The following is a description of a gene set: studied in species Homo sapiens Human Gene Set: GOBP_POSITIVE_REGULATION_OF_CYTOKINE_PRODUCTION Any process that activates or increases the frequency, rate or extent of production of a cytokine., and this is the list of marker genes: KPNA6, SELENOK, POU2F2, CAMP, FRMD8, ZC3HAV1, CCR7, TREM2, HYAL2, LPL, PLA2R1, EIF2AK2, OPA1, RAB2B, IL17RA, RPS3, PLA2G1B, ADRA2A, PANX2, SECTM1, ADAM10, CD34, FCGR2A, IL12RB1 (interleukin 12 receptor subunit beta 1), ADCYAP1, IL7, UAP1, RARA, TRPV4, TLR1, NLRP1, TSLP (NCBI Gene Id 85480), FLOT1, SPTBN1, GDF2, CYP1B1, IL36A, MAPKAPK2, MAVS, CD86 (NCBI Gene Id 942, CD86 molecule), IRF7, CCR2, NOS2, HPSE, CLNK, XIAP, TRIM32, TXK (NCBI Gene Id 7294), LILRB2, PF4, WNT11, LAMTOR5, TLR4 (NCBI Gene Id 7099), BTNL2, IRF1, CLECL1P, GATA4, IL1RAP, NFATC4, MAPK9, CD4, STING1, FCGR2C, IRAK1, IL6, SCRIB, CD36, CHUK, HGF, ADAM8, SASH3, PAEP, CCL3 (C-C motif chemokine ligand 3), DEFB131A, TANK, DDIT3, HLA-DPB1, USP50, BCL3, MIR132, CD276, HMSD, POSTN, CRTAM, PTPN22, IDO1, CASP1, PARK7 (NCBI Gene Id 113880), IRF5, SETD2, CEACAM20, MAP3K7, DDX1, TBK1, POLR3D, CYBA, VTCN1, CCL1, GPSM3, ADIPOQ, MCOLN2, BSG, PANX1, CX3CL1, FCER1G, TMIGD2, ATF4, KLRC4-KLRK1, TWIST1, NOX5 (NADPH oxidase 5), CLEC5A, IFNG, IL12RB2, IL12A, AZU1, POLR3A, CD74, CD83, C1QTNF3, KIR2DL4, OAS3, IL4R, RELA, ABCC8, HRAS, DENND1B, SERPINB7, XCL1, CHI3L1, IKBKE, IL15, TLR7, IFNGR1, IL6ST, FCGR1BP, CARD9, RIGI, C3, NMB, ISL1, MIR27B, RIOK3, PIK3R1, PANX3, LILRB1, THBS1, UNC93B1, SPON2, CD40LG, CEBPG, SPHK1, TICAM1, CLU, BTN3A1, FFAR3, IL32, RUNX1, PLCB1, STMP1, IL26, IL17RB, RAB7B, DHX9, KPNA2, ADORA2B, IL4, HTR2A, CEBPB, TRIM27, NLRC4, TMED10, HSP90AA1, NLRP2, HAVCR2, CCDC88B, KIT, NLRP9, AGER, NAIP, KAT2A, SULF2, CCBE1, RBM47, NR1H4, NRDC, S100A13, TRAF6, RIPK2, SIRT1, CRLF2, BCL10, SLC7A5, LTB, DRD2, LILRA5, CLEC9A, CADM1, TMF1, LGALS9, RAB1A, NLRP12, RAD21, STOML2, IL6R, C3AR1, SMAD3, GPRC5B, AGPAT1, SETD4, SOD1, SLC11A1, CSF1R, KLRF2, PQBP1, LUM, CAMK4, TLR2, IL1RL2 (NCBI Gene Id 8808), TYROBP, PTPRC, STAT5A, ZBTB7B, CLEC6A, MIR657, MYB, PRKCQ, OAS2, PTPN11, CSF2, PLCG2, CD3E (NCBI Gene Id 916), PYCARD, CD274, B2M, PDE4D, G3BP1 (NCBI Gene Id 10146), CARD11, ARFGEF2, IL33, TRIM56, SLAMF1, CD6, ATP6AP2, TNFSF4, ANXA1, MBP, MIR145, POLR3G, NR4A3, ISG15, POU2AF1, IL21 (interleukin 21), CYRIB, HSPA1A, TYK2, DDX21, EIF2AK3, IRF4, CARD8, NODAL, TLR8, HEG1, CD2, MIR21, RORA, IL17RC, FGR, CLEC12A, HILPDA, CXCL17, IL23R (interleukin 23 receptor), PRKCZ, IRF8, TNF, ALOX15B, IL12B (interleukin 12B), PTGS2, ARID5A, SIGLEC16, NOD1, CYBB, MAPK13, SEMA7A, WNT3A, LY9, KLRK1, DHX36, SYK, NLRP3, AKIRIN2, AIRE, MALT1, HK1, F3, ZNF580, TRIM65, EPHB2, IL16, MIR206, HSPA1B, NLRP10, PNP, XBP1, IRAK3, FFAR2, EBI3, LURAP1, ZBTB20, CD28, HSPB1, NOD2, HMGB2 (NCBI Gene Id 3148), SULF1, LRRK2, IL23A, TMEM106A, TLR5, POLR3B, BTK, IL17A, IL27RA, DDX3X, RGCC, SERPINF2, PRKD2, PTPRJ, IL17B, IL20RB, GSDMD, MIR17, PDE4B, CD46 (CD46 molecule), BRCA1, CASP8, BMPR1A, MMP8, GLMN, ADAM17, LACC1, MIF, CCL19, LBP, ORM2, NOX1, FOXP1, HHLA2, AIM2, HLA-E, EPX, WNT5A, SAA1, ORM1, IL17F, GARIN5A, CD58, DHX33, TRAF3IP3, AGT, EREG, IL27, ARRDC4, STAT3, FCN1, LEP, ROCK2, TLR3, IL18R1, GBP5, AGPAT2, GATA3, SERPINE1, CD160, HLA-A, MAPK14, APOA2, PIK3CG, ARHGEF2, AIF1, FERMT1, SPN, IL2, IL17D, FLT4, IL1A (NCBI Gene Id 3552), DEFA5, TICAM2, MYD88, TIGIT, ATF2, IFNL1, ARNT, RNF135, TRAF3, HTR2B, SPHK2, HIF1A, LAPTM5, C1QTNF4 (NCBI Gene Id 83846), SCIMP, IL10, FADD, IL13, CD14, CALCA (calcitonin related polypeptide alpha), DHX58, IFI16, HLA-G, AFAP1L2, C5AR1, PHB1, FCGR1A, LILRA2, USP22, ELANE, UCN, CREB1, RSAD2, PIK3CD, HDAC2, P2RX7, RAET1G, RFTN1, BATF, TIRAP, AKAP12, IFIH1, STAT1, RTN4, CD81, CD226, MAPK11, IL1B, PTGER4, FCGR3A, ZP3, GPR65, MIR675 (NCBI Gene Id 102724852), TRAF2, TOMM70, FZD5, CHIA (NCBI Gene Id 27159), CGAS, APPL1, INAVA, CLEC4E, DDT, HSPD1, HMOX1, IL1RL1, MIR149, GAPDH, TLR9, BTN3A2 (butyrophilin subfamily 3 member A2), FOXP3, HLA-F, IL18, HMHB1, TNFRSF8, NFAM1, NMBR, MMP12, PLA2G3, LY96, TBX21, ZCCHC3, SORL1, ZFPM1, MIR324, CLEC7A, TGFB1, MIR182, DEFB124 (defensin beta 124), SCAMP5 (NCBI Gene Id 192683), PYDC1, CD200, F2RL1, TRIM16, TLR6, INS, HMGB1, MEFV, RIPK1, HLA-DPA1, C5, TUSC2, F2R, ABL1, IGHD, PRG3, TRIM6, EGR1, OSM, MIR144, TRIM15, OAS1, IL1R1, IRF3, SLAMF6, PRG2, CD7, MDK, JAK2, LTA, ITK, IL9, POLR3C, APP, PSEN1, CD55, PIBF1 (NCBI Gene Id 10464), POLR3F, CD40, CD80, STAT5B, CD244, PELI1, TNFRSF14, MIR92A1, FCGR2B